The following is a description of a gene set: from publication Pujana MA, Han JD, Starita LM, Stevens KN, Tewari M, Ahn JS, Rennert G, Moreno V, Kirchhoff T, Gold B, Assmann V, Elshamy WM, Rual JF, Levine D, Rozek LS, Gelman RS, Gunsalus KC, Greenberg RA, Sobhian B, Bertin N, Venkatesan K, Ayivi-Guedehoussou N, Solé X, Hernández P, Lázaro C, Nathanson KL, Weber BL, Cusick ME, Hill DE, Offit K, Livingston DM, Gruber SB, Parvin JD, Vidal M (PMID 17922014) studied in species Homo sapiens Genes constituting the BRCA-centered network (BCN). Many cancer-associated genes remain to be identified to clarify the underlying molecular mechanisms of cancer susceptibility and progression. Better understanding is also required of how mutations in cancer genes affect their products in the context of complex cellular networks. Here we have used a network modeling strategy to identify genes potentially associated with higher risk of breast cancer. Starting with four known genes encoding tumor suppressors of breast cancer, we combined gene expression profiling with functional genomic and proteomic (or 'omic') data from various species to generate a network containing genes linked by 866 potential functional associations. This network shows higher connectivity than expected by chance, suggesting that its components function in biologically related pathways. One of the components of the network is HMMR, encoding a centrosome subunit, for which we demonstrate previously unknown functional associations with the breast cancer-associated gene BRCA1. Two case-control studies of incident breast cancer indicate that the HMMR locus is associated with higher risk of breast cancer in humans. Our network modeling strategy should be useful for the discovery of additional cancer-associated genes. Human Gene Set: PUJANA_BRCA_CENTERED_NETWORK, and this is the list of marker genes: NAE1, AURKA, CNOT3, ESPL1 (NCBI Gene Id 9700), RECQL, IDH3B, RBBP4, SMC2, MCM2, MRE11, PAICS (NCBI Gene Id 647765), SNRPB, NEMP1, ZNHIT3, SEC31A, RNASEH2B, UBE2C, TIMELESS, BRCA1, FANCI, RB1, NCAPD2, NASP, UNG, DNMT1, DDX39B, RAD1, TMPO, CSNK2A1, DNA2, TFDP2, MAD2L1, RAD51C, POLR2B, CAD, H2AZ2, ZNF330, MSH2, DDX46, DCP2, MCM5, PSIP1, RAD54L, MAT2A, POLA1, RPA1, SKP2, MED20, TFDP1, NFYB, ASF1A, CNOT9, CDK1, EZH2, NCK1, METAP1, TTF2, HMGB2, RAD51AP1, MCM4, MYBL2 (MYB proto-oncogene like 2), DUT, COPS3, XPO1, TCERG1, GINS1, TOP1, RPIA, CDC20, CDC7, RFC3, TOP2A, HMMR, PRPS1, SUZ12, LMNB1, ABCB7, CHEK2, CCNA2, TCF3, LBR, SMC1A, SNRPA, SSBP2, SRSF11 (serine and arginine rich splicing factor 11), POLE, CHAF1A, BLM, NDC80, TAF11, KATNA1, RAD21, SMC4, PRKDC, RBBP8, PRPF4, MCM6, KIFC1, PCNA, TBCA, BRCA2, STAT5A, DEK, CPSF4, RRM1, BUB3, SMC3, RFC4, AATF, ATM, DDX39A, SLC7A1, PPP2R5C, DHFR (NCBI Gene Id 203373), EIF3H, TOPBP1, PPP1CC, SNRPA1